Given this list of marker genes HNRNPA1, GPC1, HNRNPK, PPIE, POLR2E, RPL18, PAF1, F2, H2AC18, H2AC25, CWC27, VTN, POLR2I, DDX42, POLR2L, PPIL4, CCAR1, H4C1, PAPOLA, HNRNPC, MTOR, CSTF3, SNRPD3, EFTUD2, XAB2, U2SURP, U2AF2, DYNLT1, SDC2, EXOC1, TXNL4A, SRRM1, ATG14 (autophagy related 14), HSP90AA1, DHX15, SNRPD2, CDC5L, SRRT, CPSF3, POLR2G, PRR5, GRPEL1, HNRNPA3, POLR2B, PCF11, TLR4, H2AC21, POLR2H, SF3B2, PTBP1, H2AC11, DAXX, SMNDC1, SRSF9, SNRPN, H2AC4, HNRNPU, PRPF6, TJP1, MAPKAP1, RBMX, GTF2F1, SF3B3, PABPN1, PRPF8, CLP1, HSPG2, BUD31, SDC3, ELAVL1, SF3B6, STING1, PRCC, PPIL6, H2AC1, H3C15, H2BC5, RETREG1, CGAS, SF3B1, H2AC14, H2BC11, DDX5, SRSF3, POLR2F, PUF60, FUS, POLR2K, RBM5, CPSF2, H2BC3, H2BC26, AQR, HSP90AB1, SNRPB, TAOK1, RIPK1, HSPA8 (heat shock protein family A (Hsp70) member 8), DDX46, CD2BP2, DDX3X, C4B, POLR2D, VIM, SF3A1, GPC2, HNRNPD, IFIH1, SDC4, YBX1, CAMK2G, RBM17, PML (NCBI Gene Id 5371), SRSF5, TRIM25, HNRNPF, NUDT21, CAMK2A, SKIC8, NFKBIB, SNRPE, SNRPB2, MAVS, GPC4, DNAJC8, H2BC15, CSTF2, SRSF4, H3C1 (NCBI Gene Id 8350), PHF5A, SUGP1, U2AF1, SNRPG, NRBP1, DDX23, FIP1L1, RBM10, C1QA, H2BC4, H2AC6, ISY1 (NCBI Gene Id 57461), CLEC5A, MBL2, H2BC12, POLR2C, C1S, H2AC20, CLU, PPIL3, SRSF1, CDC73, HNRNPUL1, H2BC18, SRSF2, PPIL1, CTNNB1, SNRNP40, DHX16, H2BC9, SNRPA1, SNRPF, POLR2A, HNRNPA2B1, CPSF4, BECN1, SRSF7, CAMK2B, SNW1, RICTOR, PIK3R4, NCBP2, NEK2, TAL1, H2BC17, CWC25, CSTF2T, CHERP, ALYREF, C4BPB (NCBI Gene Id 725), H2BC21, GTF2F2, UBR4, IKBKE, HNRNPL, CTNNBL1, C4A, HNRNPH1, H2BC13, MMP9, PCBP2, DHX38, RBM22, NCBP1, WDR33, SRSF6, HNRNPM, SF3B4, FASN, PIK3C3, H2AC12, SDC1, UBE2I (ubiquitin conjugating enzyme E2 I), CDC40, C4BPA, PQBP1, U2AF1L4, GPC5, HNRNPR, CTR9, ELAVL2, LY96, PRPF19, PEX19, CRNKL1, POLR2J, H2BC1, WBP11 (NCBI Gene Id 51729), APOA1, EIF4A3, CAMK2D, PCBP1, SF3A3, AUP1, SF3B5, RTF1, CPSF1, RNPS1, GPC3, AGRN, BCAS2, SRSF11, COG1, CWC15 (NCBI Gene Id 51503), CPSF6, RPTOR, NFKBIA, CPSF7 (NCBI Gene Id 79869), SNRPD1, DENCMEMSB, H2AC7, LEO1, SRRM2, MLST8, DHX9, GBF1, HNRNPH2, PLRG1, CWC22, CSTF1, GPC6, HNRNPA0, SNRNP200, GPKOW, H2BC14, SYMPK, SF3A2, PDCD6IP, STAT2 (signal transducer and activator of transcription 2), here is a description of the gene set: After translation and post-translational modification in the cytosol, endoplasmic reticulum, and ERGIC (ER-Golgi intermediate compartment), Dengue virus (DENV) proteins localize to several other compartments interacting with host proteins. Large amounts of NS1 get secreted in the bloodstream and bind to and enter other cells, modulating innate and adaptive immune processes before those cells get infected. Other proteins affecting immune responses in infected cells are C, prM, the NS2B3 protease complex, and NS5. C and NS5 localize to the nucleus, where they also modulate apoptosis. Extracellular NS1 and nuclear NS5 contribute to Dengue hemorrhagic fever (DHF) by binding cell-junction proteins. The NS3 protein can be imported into mitochondria. For a general review, see Zeidler et al., 2017. Recent proteomic results include Karyala et al., 2016; Dey & Mukhopadhyay, 2017; Shah et al., 2018; reviewed in Carlin & Shresta, 2019. Reactome Pathway: Dengue Virus-Host Interactions studied in species Homo sapiens part of: Dengue Virus Infection